Given this list of marker genes Cst5, Ift80, Bmp6, Bmpr2, Trip11 (NCBI Gene Id 77143), Sik3, Bmpr1b, Fgf18, Alpl, Cer1, Stc1, Hoxd11, Tmem119, Mmp14 (NCBI Gene Id 17387), Axin2, Dlx5, Sox9, Phospho1 (phosphatase, orphan 1), Col13a1, Smpd3, Thbs1, Mmp13, Trpv4, Scx, Nppc, Npr2, Carm1, Por, Nfix, Dspp, Hoxa11, Col3a1, Mmp16, Mef2d, Col2a1, Col10a1, Foxc1, Atf2, Col1a1, Poc1a, Rarb, Nab2, Rara, Bpnt2, Csgalnact1, Mef2c, Galnt3, Cbs, Thbs3, Gnas, Hspg2, Rarg, Scube2, Nab1, Shox2, Ext1, Runx2, Matn1, Ihh, Tgfbr2, Comp (cartilage oligomeric matrix protein), Serpinh1, Ext2, Pex7, Inppl1 (NCBI Gene Id 16332), Col27a1, Zmpste24 (NCBI Gene Id 230709), Bmp4, Fosl2, Enpp1, Pthlh, Col9a1, here is a description of the gene set: Mouse Gene Set: GOBP_ENDOCHONDRAL_BONE_MORPHOGENESIS species: Mus musculus The process in which bones are generated and organized as a result of the conversion of initial cartilaginous anlage into bone.